The following is a description of a gene set: This event has been computationally inferred from an event that has been demonstrated in another species.<p>The inference is based on the homology mapping from PANTHER. Briefly, reactions for which all involved PhysicalEntities (in input, output and catalyst) have a mapped orthologue/paralogue (for complexes at least 75% of components must have a mapping) are inferred to the other species. studied in species Mus musculus Reactome Pathway: Programmed Cell Death electronically inferred by orthology from the curated human pathway, and this is the list of marker genes: Flot1, Cycs, Opa1, Cdc37, Dnm1l, Il1a, Mapk3, Kpna1, Hmgb1, Chmp2a, Ctnnb1, Casp8, H1f4, Dffa, Gas2, Septin4, Casp1, Ywhae, Casp7, Bad, Flot2, Ticam2, Mapt, Sh3glb2, Nmt1, Elane, Bcl2l1, Gzmb, Casp4, Dffb, Fadd, Ocln, Bak1, Gsdmd, Ywhah, Kpnb1, Birc3, H1f1, Sfn, Chmp2b, Dynll1, Bax, H1f5, Vim, Add1, Lmnb1, Tradd, Tlr4, Hmgb2, Fnta, Sdcbp, Prkn, Apip, Casp6, Aven, Lmna, Mlkl, Bcap31, Pmaip1, Fasl (NCBI Gene Id 14103), Ppp3cc, Ly96, Oma1, Mapk8, Cd14, Fas, H1f3, Rps27a, Casp3, Casp9, Ptk2, Ppp3r1, Cdh1, Dsg1a, Dsg3, Gsn, Stk26, Ubb